The following is a description of a gene set: species: Mus musculus The repair of alkylation damage in DNA, e.g. the removal of a non-physiological alkyl group from a nucleobase. This is usually mediated by DNA alkyltransferases. Mouse Gene Set: GOBP_DNA_ALKYLATION_REPAIR, and this is the list of marker genes: Mgmt, Usp7, Ascc3, Ascc1, Otud4, Fto (NCBI Gene Id 26383), Usp9x, Alkbh2, Alkbh3